The following is a description of a gene set: Reactome Pathway: SUMO is transferred from E1 to E2 (UBE2I, UBC9) SUMO is transferred from cysteine-173 of UBA2 to cysteine-93 of UBC9 (UBE2I) in a transthiolation reaction. UBC9 is the only known E2 enzyme for SUMO and on certain substrates such as RanGAP1 may act without the requirement of an E3 ligase. species: Homo sapiens part of: Processing and activation of SUMO, and this is the list of marker genes: RWDD3, SAE1, SUMO1, SUMO2, UBA2, UBE2I, SUMO3